The following is a description of a gene set: studied in species Homo sapiens An abnormality of the outflow tract of the left ventricle. Human Gene Set: HP_ABNORMAL_LEFT_VENTRICULAR_OUTFLOW_TRACT_MORPHOLOGY Abnormal left ventricular outflow tract morphology, and this is the list of marker genes: SMAD6, ADAMTS19 (ADAM metallopeptidase with thrombospondin type 1 motif 19), PTPN11, HDAC4, NKX2-5, TAB2, IFIH1, ALG9, ACTC1, NOTCH1, MYLK2, PIGL, BUB1, GNB2, CAV3, BUB1B, ZIC3, FGFR1, MYH7, SYT2, BUB3, FOCAD, GATA5, CEP57, WDPCP, TRIP13, MYH6